The following is a description of a gene set: studied in species Mus musculus mitochondrial fatty acid beta-oxidation of saturated fatty acids Mouse Gene Set: REACTOME_MITOCHONDRIAL_FATTY_ACID_BETA_OXIDATION_OF_SATURATED_FATTY_ACIDS, and this is the list of marker genes: Acadl, Mecr, Hadhb, Acadm, Echs1, Hadh, Acads, Hadha (hydroxyacyl-CoA dehydrogenase trifunctional multienzyme complex subunit alpha), Acadvl